Given this list of marker genes IRF1, SOCS1 (NCBI Gene Id 8651), CYBB, PSMB9, OAS1, IFNGR1, IFNGR2, JAK1, PRKCD, ISG15, EIF2AK2, IL1B, CXCL9, IRF4, IRF8, IFIT2, SPI1, H4C14, SOCS3, HLA-B, IFNB1, IFI6, TAP1, IFNG, REG1A, NOS2, IRF2, GBP1, STAT2, CIITA, JAK2, IRF9, CXCL10, ICAM1, IFNA2, PTPN11, STAT1, here is a description of the gene set: Human Gene Set: WP_TYPE_II_INTERFERON_SIGNALING studied in species Homo sapiens Type II interferon signaling